Given this list of marker genes Tamm41, Pcyt2, Pcyt1a, Cds1 (CDP-diacylglycerol synthase 1), Cmas, Cds2, Trnt1, Crppa, Pcyt1b, here is a description of the gene set: Catalysis of the transfer of a cytidylyl group to an acceptor. Mouse Gene Set: GOMF_CYTIDYLYLTRANSFERASE_ACTIVITY species: Mus musculus